Given this list of marker genes Stmn2, Lgals3, H2-Ab1, Hsp90ab1, Cd81, Ubc, Slfn5, Cdc42ep3, Tap2, Psme2, H2-K1, Cxcl10, Irf8, Psmb9, Slc6a6 (solute carrier family 6 (neurotransmitter transporter, taurine), member 6), AW112010, Tap1, Vcam1, Rnd1, Pttg1, Rsad2, H2-D1, Icam2, Ifit3, Plac9, Irgm1, Gm12216, Nfe2l2, Jun, Hspa1a, B2m, Tspan13, Ifit1, Rdx, S100a6, Aldh2, Cdkn1a, Capg, Plaat3, Cxcl9, Emp2, Grina, Malat1, Slc3a2, Crip1, Gbp2, Tgtp2, Igtp, Pcp4l1, Dnaja1, Gstp1, Zfp36, Chmp2a, Anxa3, Cd300lg, Meox2, Gstm1, Ly6a (lymphocyte antigen 6 family member A), Actg1, Gbp6, Gbp4, Palmd, Xdh, Cd74, Car8, Nop58, Mndal, Cd274, Iigp1, Atf4, Jam2, Gbp3, Mgll, Ifi47, Irf1, Arpc3, Cxcl12, Cytl1, H2-Aa, Alpl, Slfn2, Rps28, Cd36, Gbp7, Ly6c1, Eif2s2, Pls3, Gbp5, Apol10b (apolipoprotein L 10B), Atf3, Prr13, Cct4, Parp14, Itm2b (NCBI Gene Id 214227), Ccnd2, Tspo, H2-Eb1, Timp4, Sod1, Srrm2, Clic5, Tbrg1, Klf2, Plscr2, Cyp4b1, Il6, Ppa1 (NCBI Gene Id 67895), Sncg, Kdr, Egr1, Ddx5, Rabac1, Kitl, Abcg2, H2-Q4, Tra2b, App, Tubb4b, Fmo2, Pkm, Plscr1 (NCBI Gene Id 54533), Psmb8, Srsf7, Bst2, Calm1, Tnfsf9, Ifi203, H2-T23, Oat, Isg15, Arcn1, Arl6ip1, Tmod3, Ctnna1, Hsp90aa1, Tuba1b (NCBI Gene Id 22143), Vwa1, Psme1, Tm4sf1, here is a description of the gene set: Mouse Gene Set: TABULA_MURIS_SENIS_LIMB_MUSCLE_ENDOTHELIAL_CELL_AGEING species: Mus musculus from publication Tabula Muris Consortium (PMID 32669714)